The following is a description of a gene set: Transcriptional regulation by RUNX1 studied in species Mus musculus Mouse Gene Set: REACTOME_TRANSCRIPTIONAL_REGULATION_BY_RUNX1, and this is the list of marker genes: Psmd1, Rnf2, Ep300, Ubc, Psma6, H4c18, H2bc14, Psmd2, H2ac22, Elf1, Rps27a, Smarcc2, H2ac6, H3c4, H2az2, Lmo1, Ring1, H2bc4, H3c10, Actl6b, H4c14, Psma5, Actl6a, Elf2, H4c1, Pbrm1, Rybp, Psma3, H4c11, H2ac12, H2ac11, Kat2b, Ccnd3, Psma2, H2ab3, H2ac10, Smarce1, Uba52, H2ab2, Phc3, Bmi1, H2ac20, Smarcd1, H2bc13, Hdac1, Wdr5, H2ac23, Tcf3, Prmt6, H2ac15, Foxp3 (NCBI Gene Id 20371, forkhead box P3), H3c6, H2ac24, H2bc6, Esr1, H2bc23, Psmd12, Psmd11, Cbfb, Kmt2b, H4c4, BC051665, Rbbp5, Gata1, H2ac8, Kmt2a, H3f3b, Psma7, H3c2, H2bc9, Pml, H2bc3, Mnat1 (menage a trois 1), Psmd13, Setd1a, Smarcd3, Gata2 (NCBI Gene Id 14461), H2ab1, Psmb1, Ubb, Pax5, Psmc3, Pcgf5, Psma1, Gata3, Ccnd1, Psmc6, H2ac19, Zfpm1, H2ac18, H2bc15, H4c16 (H4 histone 16), Arid1a, Prmt1, Ctsk, H3c7, Sin3a, Itch, Cbx8, Serpinb13, Setd1b, H4c17, H2bc21, Cbx6, Trp73, Psmd6, Psmd7, Smarcb1, Psmd8, Csnk2a2, Abl1, H3f3a, Adrm1, Psmd14, H4c9, H4c2, Auts2, Psmb6, H2bc8, H2bc1, H2ax, H3c13, Phc1, Psmb7, Uba52rt (NCBI Gene Id 676687), H2bc22, H2bc7, Psma4, Sin3b, H4c8, H2aj, H2bc24, Tcf12, Cdk7, Ash2l, Csnk2a1, Psmb5, H3c14, Psmc2, Csnk2b, Ccnh, H2bc11, Psmb3, Hipk2, Psmd3, Scmh1, Lmo2, Psmc1, Yap1, Smarcd2, Ctsl, Kmt2d, H2ac13, H4c6, H3c11, Phc2, Smarca4, H3c8, H2bc12, H4c3, Ccnd2, H2ac7, Psmb4, H3c1, Ptpn11 (NCBI Gene Id 72646), H3c15, H2bc26, Cbx2, Smarcc1, Psmc5, Psmc4, H3c3, H2ac4, Tal1, H4c12, Yaf2, Psmb2, Cdk6, Ldb1, Cbx4